The following is a description of a gene set: Mouse Gene Set: TABULA_MURIS_SENIS_SPLEEN_MACROPHAGE_DENDRITIC_CELL_PROGENITOR_AGEING from publication Tabula Muris Consortium (PMID 32669714) species: Mus musculus, and this is the list of marker genes: S100a9, Rplp1, Rpl10, Rplp2, Rps10, S100a8, Rpl31, Rpl12